The following is a description of a gene set: studied in species Homo sapiens The gene expression program underlying the specification of human cell types is of fundamental interest. The study authors generated human cell atlases of gene expression and chromatin accessibility in fetal tissues. For gene expression, the study authors applied three-level combinatorial indexing to >110 samples representing 15 organs, ultimately profiling ~4 million single cells. The study authors leveraged the literature and other atlases to identify and annotate hundreds of cell types and subtypes, both within and across tissues. Our analyses focused on organ-specific specializations of broadly distributed cell types (such as blood, endothelial, and epithelial), sites of fetal erythropoiesis (which notably included the adrenal gland), and integration with mouse developmental atlases (such as conserved specification of blood cells). These data represent a rich resource for the exploration of in vivo human gene expression in diverse tissues and cell types. Human Gene Set: DESCARTES_FETAL_CEREBELLUM_SLC24A4_PEX5L_POSITIVE_CELLS Marker genes curated from the annotated cluster as represented in the Descartes Human Gene Expression During Development database. from publication Cao J, O'Day DR, Pliner HA, Kingsley PD, Deng M, Daza RM, Zager MA, Aldinger KA, Blecher-Gonen R, Zhang F, Spielmann M, Palis J, Doherty D, Steemers FJ, Glass IA, Trapnell C, Shendure J (PMID 33184181), and this is the list of marker genes: KLF2P2, OPRD1, OTOF, GOLT1A, RNA5SP87, VSTM2A-OT1 (NCBI Gene Id 285878), DDX50P2, SCUBE1, ALPK2, DCHS2, RNU6-1222P, HTR1E, L3MBTL4, ZNF860, ENSG00000226249, LPA, FNDC9, PEX5L-AS2, PEX5L, LINC02153, LINC01508, SLC24A4, RNA5SP269, C8orf34-AS1, PTPRK, PCP4L1 (Purkinje cell protein 4 like 1), LINC01982, DMBX1 (diencephalon/mesencephalon homeobox 1), KCNQ5, SCN7A, ANAPC1P1, PPP3R2, ZIM2-AS1 (ZIM2 antisense RNA 1), TRPC7, HNF4G, GRIN3A, LINC01210, MANCR, ENSG00000237720, GPR149, CLC, ZFHX4-AS1 (ZFHX4 antisense RNA 1), RGS13, LGI2, PNMA6F, ZPLD1, TLL2, C6, LIPN, IL31RA, RNA5SP180, LINC01151, ANKRD20A11P, C8orf34, SAMD5